The following is a description of a gene set: Human Gene Set: GSE3920_UNTREATED_VS_IFNG_TREATED_ENDOTHELIAL_CELL_DN species: Homo sapiens Genes down-regulated in endothelial cells: untreated versus IFNG. IFNs are highly pleiotropic cytokines also endowed with marked anti-angiogenic activity. In this study, the mRNA expression profiles of endothelial cells (EC) exposed in vitro to IFN-alpha, IFN-beta, or IFN-gamma were determined. We found that in HUVEC as well as in other EC types genes were upregulated (>2-fold increase) by IFNs, including genes involved in the host response to RNA viruses, inflammation, and apoptosis. Interestingly, genes showed a >5-fold higher induction by IFN-alpha in EC compared to human fibroblasts; among them, the gene encoding the angiostatic chemokine CXCL11 was selectively induced by IFN-alpha in EC along with other genes associated with angiogenesis regulation, including CXCL10, TRAIL, and guanylate binding protein 1 (GBP-1). These transcriptional changes were confirmed and extended by quantitative PCR analysis and ELISA; whereas IFN-alpha and IFN-beta exerted virtually identical effects on transcriptome modulation, a differential gene regulation by type I and type II IFN emerged, especially as far as quantitative aspects were concerned. In vivo, IFN-alpha-producing tumors over-expressed murine CXCL10-11, GBP-1 and TRAIL, with evidence of CXCL11 production by tumor-associated EC. Overall, these findings improve our understanding of the anti-angiogenic effects of IFNs by showing that these cytokines trigger an anti-angiogenic transcriptional program in EC. Moreover, we suggest that quantitative differences in the magnitude of the transcriptional activation of IFNresponsive genes could form the basis for cell-specific transcriptional signatures. from publication Indraccolo S, Pfeffer U, Minuzzo S, Esposito G, Roni V, Mandruzzato S, Ferrari N, Anfosso L, Dell'Eva R, Noonan DM, Chieco-Bianchi L, Albini A, Amadori A (PMID 17202376), and this is the list of marker genes: PTPN11, ASB8, EDEM2, TMEM168 (NCBI Gene Id 64418), XKR8, METTL13 (NCBI Gene Id 88158), TMEM9B (TMEM9 domain family member B), ZNF106, BCKDK, SLC25A51, WDR77, CCDC71, MCM2, POLR2B, KCTD1, NUDT16, TMEM185A, NAGPA, MTMR4, PIGQ, MED18, UBQLN4, ZSWIM1, SCARB1, GRN, TRAPPC10, GBF1, MEN1, UBIAD1 (NCBI Gene Id 7801), ISOC1, MRPS2, GRK2 (NCBI Gene Id 156), LIMD1, PSMD1, CLINT1, NOMO1, POLR2M, SREK1IP1, LHPP, TMTC4, AP1AR, PFKL, HIPK3, PCYOX1, CTSZ, PSMB5, SGPP1, TGM2, XPNPEP1 (NCBI Gene Id 7513), GART, SPTLC2, AGO1, FADS1, AKAP1, FAM20B, GNA12, MRPL11, CENPV (NCBI Gene Id 201161), SETD3, MEX3D, MRPL14, TYRO3, AQP9, DDB1, KIF1C, TSFM, SEC23IP, KPNA6, GTF2H4, PREP, FBXL14, TBC1D14, PIGS, SNAP23, PATZ1, PLXNB2, H6PD, DEF8, GATD1 (glutamine amidotransferase class 1 domain containing 1), LEPROT, PHLPP2, ERMP1, KBTBD11, TRIM7, GATAD1, SSX2IP, FBXO5, HEXIM2, LPCAT3, ZFTRAF1, SDC3, ZDHHC3, TMED7, THOC3, TRAM1 (NCBI Gene Id 23471), TMCO1, ALG11, MRPL44, PFAS, DNAJA3, SUPT7L, CAD, NUP160, ANAPC1, TMEM41A, PBK, SLC25A44, USP21, JAGN1, LASP1, SLC39A3 (NCBI Gene Id 92729), LEPROTL1, CLSTN3, TRIM32, PBRM1, TBL1XR1, MLEC, RETREG2, TSC2, CINP, PCCB (propionyl-CoA carboxylase subunit beta), OXSM, SLC25A16, AMFR, ALAD, SRD5A3, SNAPC2, ATG9B, CHTF8, TEX261, GPD1L, UBE4B, NAPEPLD, EXTL2, LAMTOR3, BLOC1S6, ZBTB22, PLRG1, PIGC, PRPF8, CDK19, ELP2, MESD, CSNK2A1, DGCR8, ABHD8, CDCA7, SPCS3, PCYT1B, SRM, PHF2, FGFR1OP2, NDUFAF1, LGALS3BP, KCTD21, NDUFS7, MTMR3, TMEM50B, CTSS, MTFR1L, USB1, PLIN3, ITPRIPL1, MBD3, MFSD1, TMEM177, TIMELESS, PIK3R4 (NCBI Gene Id 30849), PES1, TARBP1 (TAR (HIV-1) RNA binding protein 1), NPC1 (NPC intracellular cholesterol transporter 1), JTB, MIGA1, RMDN3, SEC24C, MAEA, NACC1, NUDT1, MED23, LRRC8C, COPA, METTL8, WDR18, DFFA